The following is a description of a gene set: A membrane coat found on coated pits and some coated vesicles; consists of polymerized clathrin triskelions, each comprising three clathrin heavy chains and three clathrin light chains, linked to the membrane via one of the AP adaptor complexes. Mouse Gene Set: GOCC_CLATHRIN_COAT studied in species Mus musculus, and this is the list of marker genes: Lrrn3, Btbd8, Snap91, Ap3b1, Cltb, Ap3m2, Slc18a3, Kcnq5, Sclt1, Aak1, Baiap2l2, Ap2a2, Ap1b1, Ap4b1, Clta, Synrg, Enthd1, Ap1s3, Ap1m2, Sgip1, Ap2a1, Ap2s1, Necap1 (NCBI Gene Id 67602), Tbc1d5, Ap1s2 (NCBI Gene Id 68960), Clba1, Epn3, Eps15l1, Eps15, Igf2r, Ap2b1, Epn1 (epsin 1), Ap1s1, Picalm, Synj1, Aftph, Cltc, Vps41, Epn2, Ap1g1, Ap3m1, Necap2, Scn10a, Clint1, Ap1m1, Vps33a, Ap2m1, Dab2, Ap4m1, Ap1g2, Ston2, Ston1